The following is a description of a gene set: Human Gene Set: GOCC_NEURON_PROJECTION_CYTOPLASM species: Homo sapiens All of the contents of a plasma membrane bounded neuron projection, excluding the plasma membrane surrounding the projection., and this is the list of marker genes: TMEM108, ABHD13, TRAK2, DTNBP1 (NCBI Gene Id 84062), KIF4A, ACTR10, KIF5B, HIP1R, AP3S2, KIF1C, HSBP1, GRIK3, KIF3A, MAP1A, NEFL, FLOT2, MAP2K1, ARL8B, BLOC1S5, FBXW11, ARMCX3, KIFC2, WASF1, AP3B2, NETO1, UHMK1, KIF21A, GRIK2, AP3D1, NDEL1, SPAST, HNRNPAB (heterogeneous nuclear ribonucleoprotein A/B), ARL8A, LRRK2, DYNLL1, FMR1, BLOC1S4, CDKL5, OPA1, ABHD12, KIF17, TRAK1, MGARP, KIF1B, KIFAP3, BLOC1S3, RANGAP1, ZC3H14, BLOC1S1, KIF5C, HSPB1, SNAPIN, SYBU, SOD1, AP3B1, BLOC1S6, PQBP1, TRIM46, AGBL4, HAP1, RAB27B, DST, SPG7, DYNC1H1, HDAC6, HPCA, PAFAH1B1, BLOC1S2, STAU2, AP3M2, MAPK8IP3, EIF4EBP2, KIF3B, RAB17, DLG2, STAU1, RAB21, BAIAP2, CHRNA2, MAP2 (NCBI Gene Id 4133), AP3M1 (NCBI Gene Id 26985), AP3S1, AGTPBP1, HIF1A, DLG4, MAPT, UCHL1, KIF5A, ARC, KIF1A